Given this list of marker genes MYBL1, SND1-IT1, CD1E, STXBP5L, EIF2AK2, DCLK1, TPD52, RSAD2 (NCBI Gene Id 91543), RPS26, LRPPRC, SETD2, PPP2R1A, TRIM22, ZSWIM8, SERPINA5, OLFM1, GRP (NCBI Gene Id 2922), SYNGR4, MAGEA5P, DDX18, RUVBL2 (RuvB like AAA ATPase 2), HNF1B, DMXL1, RAC2, ALOX5AP, NTNG1, CD28, ACSL1, KIF14, IDH1, STIP1, COL5A2, EPHA7, POGZ, RAD9A, TBX1, CARD8, FASTKD2, CES1, FLT4, SRR, HSP90AB1, IQCB1, NR1H3, CCNT1, LILRB2, OTUD3, KLHL4, BAZ2B, OGA, NORAD, ARHGDIB, SP100, DHRS2, EIF4E2, MID1, LIG3, NDST1, DNAJB4, INVS, NEDD8, LRP8, CXCL10, CD79B, CAV2, MKNK2, HP, RPE, ATP6V1E1, CTAG2, PPID, CDK4, DYNLT1, PPP2R2B, PRKCB, QRICH1, GLA, BRD2, DUSP6, EIF4E, MAMLD1, RPL39, SRSF3, ANG, PPP1CB, MLF2, NUP160, TGIF1 (TGFB induced factor homeobox 1), ISG15, SCN5A, COBLL1, GUCY2F, TDRD7, MLANA, APOL1, FOXC2, BUD23, EXTL3 (exostosin like glycosyltransferase 3), HDLBP, WSCD2, TSPYL2, CD163, PRAME, ARHGAP12, PEX13, CLIP1, INTS3, ORC5, DIXDC1, DDAH1, CLCNKA, SLC25A24, IFITM1, MICA, SMYD2, PRDM1, CD33, GABPA, PSMB9, TSR1, PSME2, HMGB3P30, TULP1, NAT1, GALT, GJB1 (gap junction protein beta 1), ZNF711, GRB2, SNRNP35, PLEKHG3, GATC, FOS, CPT1B, POU2F1, HOXA10, GNGT1, NPRL3, CYBB, CD40, LECT2, TRIM21, TMED9, PGM5, BRS3, SUPT20H, TOM1, MPDZ, SULT1C2 (NCBI Gene Id 6819), TCAF1, OPTN, GCNT2, FAS, GPRC5B, EEF1E1, NNAT, RARRES2, AATF, MARK3, RAP1GAP, ZNF85, EFNB2, TLR2, N4BP2L2-IT2, SLC16A2 (NCBI Gene Id 6567), PRIM2, SOD2, SLC31A1, TSPOAP1, MMP8, IFNA21, ZBED1, MX2, HTRA1, CKS2, ERCC6, RPL3, IFIT1, PBX1, FCGR3B, SERPINB9, TXNIP (NCBI Gene Id 10628), THOC2, FPGS, LDHC, TGM3, PRODH2 (proline dehydrogenase 2), ATP2A2, CYP27B1, WDR43, CRYM, IRX3, RASGRP1, TOP6BL, OFD1 (NCBI Gene Id 8481, OFD1 centriole and centriolar satellite protein), CA12, CHRDL1, ACOX2, TGFB3, PPP1R10, here is a description of the gene set: Genes down-regulated in comparison of dendritic cells (DC) exposed to L. major versus DCs exposed to M. tuberculosis. from publication Chaussabel D, Semnani RT, McDowell MA, Sacks D, Sher A, Nutman TB (PMID 12663451) species: Homo sapiens Monocyte-derived dendritic cells (DC) and macrophages (MΦ) generated in vitro from the same individual blood donors were exposed to five different pathogens, and gene expression profiles were assessed by microarray analysis. Responses to Mycobacterium tuberculosis and to phylogenetically distinct protozoan (Leishmania major, L. donovani, Toxoplasma gondii) and helminth (Brugia malayi) parasites were examined, each of which produces chronic infections in humans yet vary considerably in the nature of the immune responses they trigger. Human Gene Set: GSE360_L_MAJOR_VS_M_TUBERCULOSIS_DC_DN